The following is a description of a gene set: Narrow internal auditory canal Reduction in diameter of the internal auditory canal. species: Homo sapiens Human Gene Set: HP_NARROW_INTERNAL_AUDITORY_CANAL, and this is the list of marker genes: TCOF1 (NCBI Gene Id 6949), SALL4, MAFB, TWIST1, OTX2, AKT1, PRRX1, ERF, POLR1B, FGFR3, CHN1, POLR1D, ANKH, POLR1C, FGFR2